Given this list of marker genes Cd274, Lrrfip2, Irf3, Tlr4, Cd300lf, Prkce, Ticam2, Tlr6 (NCBI Gene Id 21899), Rab11fip2, Ticam1, Tnip3, Irf7, Sarm1, here is a description of the gene set: Mouse Gene Set: GOBP_MYD88_INDEPENDENT_TOLL_LIKE_RECEPTOR_SIGNALING_PATHWAY A toll-like receptor signaling pathway not relying on the MyD88 adaptor molecule. Toll-like receptors directly bind pattern motifs from a variety of microbial sources to initiate innate an immune response. species: Mus musculus